The following is a description of a gene set: studied in species Mus musculus Mouse Gene Set: GOBP_NEGATIVE_REGULATION_OF_VASCULAR_ASSOCIATED_SMOOTH_MUSCLE_CELL_DIFFERENTIATION Any process that stops, prevents or reduces the frequency, rate or extent of vascular smooth muscle cell differentiation., and this is the list of marker genes: Fgf9, Dnmt1, Nfatc1 (nuclear factor of activated T cells, cytoplasmic, calcineurin dependent 1), Hey2, Nfatc3, Nfatc2, Pdgfb, Pdcd4